The following is a description of a gene set: Mouse Gene Set: GOBP_ANTIBACTERIAL_PEPTIDE_PRODUCTION studied in species Mus musculus The synthesis or release of an antibacterial peptide during an immune response, resulting in an increase in intracellular or extracellular levels., and this is the list of marker genes: Nod2, Mmp7, Evpl, Klk7, Pgc, Elane (NCBI Gene Id 50701), Ivl, Ppl, Klk5 (NCBI Gene Id 68668), Lgals4